The following is a description of a gene set: Genes having at least one occurrence of the motif NCNRNNGRCNGTTGGKGG in the regions spanning 4 kb centered on their transcription starting sites. This matches the MYB transcription factor binding site V$CMYB_01 (v7.4 TRANSFAC). species: Homo sapiens Human Gene Set: CMYB_01, and this is the list of marker genes: GPR21, MFN1, TMEM109, RBBP6, NUFIP2 (nuclear FMR1 interacting protein 2), CDC27, PIK3R3, SLC9C2, IGFBP4, ITGA5, SOBP, NOVA2, HEBP1, HNRNPH3, YBX3, NCOA5, MED26, PER1, GPC4, ARL6IP6, TYRO3, ARHGAP12, OARD1, PELP1, PITX2, SASS6, FAM53C, PRR3, TRMT2A, LMO3, GNB2, SLC39A3, NFYA, WDR90, ARF6, SCN5A (sodium voltage-gated channel alpha subunit 5), PRRT2, EYA1, CEP97, FAM13B, PNRC2, CALM3, BHLHE40, RUVBL2, CPEB4, EHMT2, AGBL5, POGZ, WAC, QRICH1, SNRPD1, TUBA3E, TOM1, PRDM10, LINC03122, MTFR1, B4GALNT1, ARHGAP45, PHOX2B, NDST2, BMAL1, IL4I1, E2F3, MTF2, TP63 (tumor protein p63), AP2B1, ZBTB49, NEDD8, FBXO34, DNAI4, TRIM37, ERG28, MLLT10, BARHL1, ADGRG4, OVOL2, YWHAZ, CFAP20, JADE2, ADD3, EPC1, PURA, TAOK2, SAE1, FGF16, KLHL35, ODF2, SH3KBP1, MNAT1, PRPF38B, KCNJ15, CACNG2, ZC2HC1C, XPO5, MAP9, NUP62, NDUFAF3, CRAT, RSBN1, ATF5, ADISSP, HOXA2, SP1, PBX1, WNT9B, HES6, EDC4 (enhancer of mRNA decapping 4), SULF1, LPCAT3, NRGN, STMN1, BAP1, PABPC1, AVPR1B, PRUNE1, CITED2, GNL1, ETV4, DALRD3, RBM6, MIER1, ITPKB, TUG1, EGR3, ASIC1, LHX1, NLK, CEP85, NR3C2, POMT1, ANGPTL5, PTCD3, ZNF462, AEBP2, DLX1, ALDH6A1, TIMP4, DIO1, MYOG, YY1AP1, SPAG9, PHF7, HEPACAM, KPNB1, PPM1E (NCBI Gene Id 22843), GMPR2, MTCH2, BHLHE22, JUND, ZBTB26, NOL4L, FGF12, OAZ2, WNT3, MINDY1, ARL8B, ZNF800, NEUROG3, PAPOLG, HR, SSNA1, STT3B, ABHD2, HNRNPA3, TGFBRAP1, BRPF1, ERLIN1, KLF5, HOXB8, ERBB4 (erb-b2 receptor tyrosine kinase 4), HELZ2, SUCO, FST, DERL3, POLH, HNF1A, H1-1, ATXN3 (ataxin 3), DTX1, NLGN2, PAFAH1B1, MORF4L2, RPL4, WNT4, CTNNA2, CDC14B, USP2, NFE2, ANAPC2, TRMT13, ASXL2, MXI1, RNF38, CBX6, ROCK1, TPM3, KMT2D, HOXB3, IL4, MANF, SPATS2, HYCC1, RALY, DNAJB1, NR2E1, ZNF148, CANX, YBX2, SCML2, STAG2, IL1RAPL1, HOXB4, RBM14, MGLL, ZBTB17, TOR1AIP1, C10orf53, KLF9, SPINT2, DHX30, ZIC4, IER5, ZNF821, PDGFB, PDZRN4, FAM91A1, PTPA, INTS9, HMBOX1, UBE2H, MAZ, BCL9L, FANCD2OS, PPIG, UBE2K, UBE2M, RHBDD3 (rhomboid domain containing 3), ARL1, VPS26A, GSK3B, VAPA, DVL2, PIK3AP1, VPS13A, ASH1L, TRAFD1, LYAR, RANBP1, PPME1, DAP3, ATP2B2, MORF4L1, APLN, RTN4, ZNF281